The following is a description of a gene set: The presence of a neoplasm of the testis with origin in a Sertoli cell. Sertoli cell neoplasm Human Gene Set: HP_SERTOLI_CELL_NEOPLASM species: Homo sapiens, and this is the list of marker genes: DICER1, KEAP1, PDE11A, PRKAR1A, STK11